Given this list of marker genes AKAP5, ARHGAP44, COMMD1, ZDHHC2, GRIPAP1, here is a description of the gene set: Any process that modulates the frequency, rate or extent of endosome to plasma membrane protein transport. species: Homo sapiens Human Gene Set: GOBP_REGULATION_OF_ENDOSOME_TO_PLASMA_MEMBRANE_PROTEIN_TRANSPORT